Given this list of marker genes Hoxa9, Bicral, Trip4, Wdr43, Zzz3, Ctbp1, Ncam2, Kras, Lce1l, Ypel2, Col4a2, Apc (APC, WNT signaling pathway regulator), Fpgt, Dennd6a, Rbl1, Zfp385b, Wdr26, Gfer, Sema6d, Celsr3, Pspc1, Cdh20, Fubp1, Ago4, Itgb3bp, Prex2, Rere, Elf2, Gnai1, Irs1, Tm6sf1 (transmembrane 6 superfamily member 1), Trhde, C2cd2, Cinp, Zfp704, Syt1, Papola (poly (A) polymerase alpha), Crkl, Tal1, Sema3c, Anks4b (NCBI Gene Id 72074), Pygo1, Dcp1a, Nol4, Cntnap2, Krtap4-2, Tnfrsf11a, Tmed8, Edil3, Hic2, Ncoa2, Rp1, Cacng3, Prrc1, Rnf152, Pramel25 (NCBI Gene Id 194227), Hycc2, Slc45a4, Inpp4b, Etv5, Tmem135, Adamts5, Bzw1, Napb, Cdx2, Chd2, Mllt3, Nrep, Acvr2a, Zfp871, Sytl4, Mmp20, Trappc13, Cgas, Susd6, Tlx1, Wipf1, Camk2d, Bcl9, Ssbp2, Angptl2, Ubxn7, Pcdh20, Gpm6b, Zdhhc15, Zfp384 (zinc finger protein 384), Dcx, AI467606, Lpcat3, Spink5, Dgkd, Ogt, Mecp2, Gdf3, Gcnt4, Atxn7l3, Zranb3, Nudcd3, Igdcc4, Txlng, Hook3, Ms4a2, Rbm25, Gpcpd1, R3hdm1, Wdr7, Zcchc12, Smad2, Slc9a6, Strbp, Zfp652, Mc4r, Dgkk, Mosmo, Nptx1, Eid1, Lamp2, Dsc2, Nus1, Slf2, Phf13 (NCBI Gene Id 230936), Tmem43, Arid4a, Pcdh7, Trappc9, Gpr25, Cnnm3, Nrsn1, Rab11a, Col4a1, Gng12, Pcdh9, Lrp8, Diras1, Ppp1r15b, Usp28, Rab14, Nipa2, Dgki, Map4k4, Tnrc6b, Ehd3, Bnc2, Cdk9, Dennd2a, Golph3l, Trpm3, Dcaf7, Pmepa1, Sall2, Sppl2a, Pcdhb13, Ikzf2, Fzd3, Srsf10, Eea1, Frk, Jcad, Prdm15, Phc3, C5ar2, Nalcn, Itpripl2, Gpa33, Slc6a19, Pigc (NCBI Gene Id 98680), Hipk1, Mob3b, Gosr1 (NCBI Gene Id 53879), Cenpw, Adamts15, Rbfox1, Fam53c, Slc25a53, Ube2k, Slc38a6, Usp34, Hacd2, Rprd1a, Arid2, Dennd4c, Prrg1, Cbfb, Dclk1, Tmem65, Rab11fip3, Ccdc82, Psd3, Poldip3, Dtx4, Nf1, Ubr5, Hnrnpa0, Cdh6 (NCBI Gene Id 12563), Pgap1, Oxr1, Cyp4a12b, Lrrc47, Yeats2, Grin1, Aip, Cldn23 (NCBI Gene Id 71908), Mtmr6, Cacna1c, Rab8b (NCBI Gene Id 235442), Krtap4-16, Eif4e, Kcnd2, Ppp3r1, Wdr37, Mctp2, Lrrc28, Nfx1, Trip12, Cbfa2t3, Erbb4, Sertad2, Senp7, Unc80, Gng2, Nat2 (NCBI Gene Id 17961), Ccdc47, Fam3c, Arhgap12, Zfp870, Chmp7, Mrpl41, Map10, Axin2, Sf1, Epc1, Fndc9, Prps2, Depdc7, Tab3, Bend4, Clock, Cnot6l, Kcnrg (NCBI Gene Id 328424), 1700028K03Rik, Pptc7, Rhpn2, Igf1r, Dzank1, Mall, Aak1, Sh3pxd2a, Nwd2, Phax, Sntg1, Polr3k, Csnk1d (NCBI Gene Id 71708), Mmrn1, Cep68, Tbr1, Kif1b, Ankrd45, Dpcd, Rbpj, Dhx36, Fam53b, Inpp5a, Snx12, Ube2d2a, Nedd1, Ube2w (ubiquitin-conjugating enzyme E2W (putative)), Map3k20, Pcmt1, Slc35e3, Malt1, Map3k8, Zfp516, Aph1c, Egln1, Slc4a8, Cdyl2, Vamp2, Mgme1, Dvl1, Onecut2, Vat1l, Herc2, Tent4b, Atg10, Ammecr1, Rpl5, Bpifc, Ube2e3, Hivep1, Rab2a, Sufu, Pten, Zbtb10, Pafah1b2, Tmem248, Epha5, Pcdh18, Donson (downstream neighbor of SON), Vezt, Uba2, Mcts1, Zfp11, Sec22c, Ptpre, Isca2, Ndfip2, Agtpbp1, Slc30a7, Crebrf, Tub, Zmat3, Zfand5, H6pd, Itgb2l, Sh3bgrl2, Gpr18, Tmem183a, Wdfy3, Ephb1, Atrx, Klhl2, Dyrk1a (NCBI Gene Id 76465), Tmem106b, Rorb, Tmem117, Rbm33, Cdkn1b, Gpatch2l, Dpf1, Hdac1, Btbd7 (NCBI Gene Id 70608), Rora, Tshz1, Pitx2, Stxbp5, Fgd6, Tm9sf2, Frmpd4, Tbc1d5, Gabra4, Zfp706, Pold3, Ctsc, Ppp6r3, Jmy, Phf12, Rmnd5a, Hipk3, Hlf, Scn2a, Aurkb, D3Ertd751e, Ptbp3, Trim33, Phf21a, Lect2, Lrrcc1, B3gnt5, Dcaf5, Cask, Vat1, Cxxc4, Atp5mc3, Pfn2, Ndrg3 (N-myc downstream regulated gene 3), Slitrk4, Tmx3, Wls, Unk, Idh3a, Cxcl16, Olr1, Slc4a10, Ppm1h, Magi2, Camkk2, Oas3, Cyp4a12a (cytochrome P450, family 4, subfamily a, polypeptide 12a), Pof1b, Bod1l, Lztfl1, Cul4a, Mier1, Herc6, Wipf2, Prlr, Nek2, Foxf1 (NCBI Gene Id 15227), here is a description of the gene set: from publication Chen Y, Wang X (PMID 31504780) Mouse Gene Set: MIR_7229_3P Genes predicted to be targets of miRBase v22 microRNA mmu_miR_7229_3p in miRDB v6.0 with MirTarget v4 prediction scores > 80 (high confidence targets). species: Mus musculus